The following is a description of a gene set: species: Homo sapiens Human Gene Set: MIR6079 Genes predicted to be targets of miRBase v22 microRNA hsa-miR-6079 in miRDB v6.0 with MirTarget v4 prediction scores > 80 (high confidence targets). from publication Chen Y, Wang X (PMID 31504780), and this is the list of marker genes: TRMT61B, TMEM168, ASCL1, ATXN3, ELL, ADGB, SHANK2, CAPN2, SACM1L, GDAP2, TET3, ATAD2B, CBX4, SLC7A6OS, SMR3B, EDDM3A, DSTN (destrin, actin depolymerizing factor), XXYLT1, SERPINB2, DACT3, GID4, HCN3, AKAP6, CYFIP2, EPB41L3, KCND2, SPOCK2, MTCL3, ZCCHC2, MYRIP, MITF, C11orf68, CFAP184, HIF3A, PTP4A1 (protein tyrosine phosphatase 4A1), TIMP2, OGT, LSM12, MSMO1, CSNK1G3 (casein kinase 1 gamma 3), LIN9, HMGN1, POLH, CFL2, CCDC71L, ZNF621, CREBRF, SEMA3C, LENG9, RALGAPA1 (Ral GTPase activating protein catalytic subunit alpha 1), PCDH11X, DHRS7, KBTBD2, SMCO3, EDEM3, ACVR2A, CAMKK2, C11orf24, HAPSTR1, EPHA6, ZNF585B, SGK2, KCNMA1, REEP3, RORA, RBFOX3, FREM1, STYX, CORO1C (coronin 1C), PRKAA1, ADO, ADAM23, ANKRD46, ILDR2, BPNT2, TMEM39A, MAGI3, CCDC87, GSKIP, GALR1, LRRN1 (leucine rich repeat neuronal 1), VPS13A, MFAP3L (NCBI Gene Id 9848), PIK3CB, VEPH1, DIAPH2, LRRK2, MTOR, CDH6, MS4A1, MEX3B, JADE1, SETD7 (NCBI Gene Id 80854), CA10, PTAR1, TRAPPC14, HNRNPD, MAU2, AK4, RBFOX1, CELF5, CDR2L (NCBI Gene Id 30850), CHURC1, ITPR2, KCNK9, ATP6V1A, LPP, RASA2, YWHAZ, VDAC3, POGK (pogo transposable element derived with KRAB domain), ITGA2, PRX, KDM5A, ULK2, RPP25, LDLRAD1, ARSG, CYP11B1, ONECUT2, LRRC39, OTUD4, MDGA1, BMPR2, FOXN3, ZNF281, TMEM41A, CDKN2AIP, MVB12B, ABR, MBTD1, ELAVL4, KRTAP4-7, SMIM17, RTN4, SCARA5, MME, GARRE1, HRH4, CANX, RAB5B, MIP, PRICKLE2, UBXN2B